The following is a description of a gene set: studied in species Homo sapiens Human Gene Set: GOBP_DNA_DAMAGE_RESPONSE Any process that results in a change in state or activity of a cell (in terms of movement, secretion, enzyme production, gene expression, etc.) as a result of a stimulus indicating damage to its DNA from environmental insults or errors during metabolism., and this is the list of marker genes: UBE2NL, FH, FANCL, INO80C, GINS4, FOXP1, AGER, IMMP2L, SLX4, IER3, CIP2A, APBB1, CRADD, PRMT6, CD44, HSF1, DTX3L, ELOF1, PCNA, FANCB (FA complementation group B), EEF1E1, UBE2E2, NPAS2, PIDD1, NSMCE3 (NCBI Gene Id 56160), INO80E, CBX5, PYCARD, FANCC, UBE2T, SUV39H1, MDM4, FANCG, OARD1, AUNIP, NKX3-1, CHEK2, FEN1, SMARCAL1, USP3, MIR193A, FANCD2, ING4, WRNIP1, ERCC3, HMGA2, DOT1L, RTEL1, RNF168, NFAT5, FUS, RPA4, ERCC6, MSH4, GFI1, KASH5, DNA2, MUS81 (NCBI Gene Id 80198), TRAF6, DNTT, GTF2H5, BAG6, SHLD2, NTHL1, EMSY, FANCM, GTSE1, MAP3K20, MMS22L, GCNA, TADA2B, UHRF1, BAD, TAOK2, PSMD10, PARP9, EGLN3, FAM111A, USP47, EP400, RNF111, XPC, FOXN3, E2F7, BRCC3, RRM2B, GTF2H4, DDX5, PRPF19, CETN2, MDC1, RFC4, TDG, LIG1 (NCBI Gene Id 3978), ZDHHC16, SMC5, PIAS1, TIPIN, HUS1B, RAD51, MCM10 (minichromosome maintenance 10 replication initiation factor), DDB1, FAAP20, PIK3R1 (phosphoinositide-3-kinase regulatory subunit 1), SGF29, MAPK14, BARD1, TPT1, TAF9B, UBE2A, RECQL5, MCM4, UBE2N, CDCA5, MCM6, CASP2, BCL7A, LYN, HPF1, BACH1, MAPK12 (NCBI Gene Id 6300), MRGBP, ACTR8, FOXO1, MIR221, MAGEF1, POLG (DNA polymerase gamma, catalytic subunit), PMS2P6, ARMT1, BCL6, ENDOV, MARCHF6-DT, RNF113A (NCBI Gene Id 7737), OOEP, PELI1, FAM168A, KDM1A, CRIP1, SEM1 (NCBI Gene Id 7979), MASTL, TDP2, PSEN1, VCP, PARG, TNF, REC8, CBX1, CXCL12, GINS2, CRY2, SETMAR, ATR, FAAP100, SMYD2, PNKP, VPS72, AP5S1, EPC2, NUDT1 (NCBI Gene Id 4521), USP45, WRAP53, WRN, STK19, HIC1, RBBP4, GTF2H1, MACROH2A1, DGKZ, SUMO1 (small ubiquitin like modifier 1), DMC1, REV3L, MUTYH, VCPIP1, ALKBH2, HMGB2 (high mobility group box 2), ZBTB7A, MIF, RHNO1, CHAF1A, INIP, BCL2L2, IFFO1, ASTE1, CDKN2A, EXO1, MBTPS1, HNRNPK, DYNLL1, ANKRD1, SNAI1, ZBTB38, RAD9B, TELO2, SPATA22, METTL3, SMARCD1, SETD1A, BCL7C, UPF1, MTREX, POLI, CBX8, DDX1, ERCC5, NRBP2, CDKN2D, FBXW7, ABRAXAS1, CDC14B, KDM2A, NFATC2, CCAR2, WAS (NCBI Gene Id 7454), PPP2R5C (NCBI Gene Id 63377), RPS6KA6, PIAS4, ATM, KAT5, DONSON, RPTOR, DCLRE1C, PLK5 (NCBI Gene Id 126520), BAZ1B, BRCA2, NABP1, TENT4A (terminal nucleotidyltransferase 4A), ZC3H12A, MGME1, CHAF1B, POLQ, RNF138, OGG1, GTF2H3, TOP3B (DNA topoisomerase III beta), ERCC2, DELE1, RFC3, MTOR, APTX, SENP3, ARID1A, MEIOC, XRCC2, MCTS1, SHISA5, WNK2, EPHA2, RAD21, RPA1, CHD1L, SKIL, MACROD2, PYHIN1, PRDM9 (PR/SET domain 9), TIGAR, HDGFL2, SKP2, MAPKAPK2, MEAF6, NFATC4, GIGYF2, POLK, TAF1, NSD2, TAF5, SPINDOC, SNW1, NRBP1, MCRS1, TRIM28, EIF2AK4 (NCBI Gene Id 440275), SPDYA, MLH1, HTATSF1, PMS2, SFRP2, CHCHD6, RPS27L, RAD54L, REV1, IRF7, INO80B, SPO11, XNDC1N, TADA3, KIF22, POLD2, RNF126, FBXO31, C1QBP, TANK, POLM, MARF1, RMI1, DHX9, STUB1, NRDE2, C11orf54, ACTB, UVRAG, RECQL4, ZCWPW1, MORC2, MAD2L2, TAOK3, TIMELESS, CEBPG, SUPT7L, CLU, ZNF668, TAF6, PDS5A, SPIRE2, NEIL2, SUSD6, RAD23B, CSNK2A2, ACER2, NFRKB, SGK1 (NCBI Gene Id 6446, serum/glucocorticoid regulated kinase 1), KIN, SIRT4, PLK3, HELQ, MRNIP, TONSL, TP53BP1 (NCBI Gene Id 7158), CCNK (cyclin K), SMCHD1, TOP3A (DNA topoisomerase III alpha), USP43, XRCC1 (X-ray repair cross complementing 1), USP10, FAAP24, BCL7B (BAF chromatin remodeling complex subunit BCL7B), SMUG1, KDM4D, BAK1, ASCC3 (activating signal cointegrator 1 complex subunit 3), ING2, CHD2, BCL2L12, PARPBP, POLR2I, UNG, CD74, BLM, MAEL, PPP4C, PMS2P5, UCHL5, SMARCB1, PCLAF, ATXN7, MDM2, INTS7, ZNHIT1, RRM1, ERCC8 (NCBI Gene Id 2075), RUVBL1, ZBTB1, SIRT1, CTBP1-DT, FIRRM, WNK1, H2AX, MSH3, TNFRSF1A, YAP1, RASSF1, TREX2, CSNK1E, NUDT16L1, SIRT7, FBXO6, RIOX1, TTI2, ELL3 (elongation factor for RNA polymerase II 3), PRAP1, VRK2, TAF4, BRD4, TFPT (TCF3 fusion partner), ERCC6L2, XRCC3, UBA1, CDK9, LIG3, NUAK1, PIF1, CUL4A, NOP53, PHLDA3, RPS3, FBXO4, PSME4, JMY, IRF3, UVSSA, TOP2A, TMEM109, NDUFS6, UBE2W, CSNK2A1, YY1, MCMDC2, RAD9A, TAF12, WDR33, ZRANB3, CCDC117, CREBBP, CDK1, MAJIN (membrane anchored junction protein), TFDP3, PTTG1, PPP1R15A (protein phosphatase 1 regulatory subunit 15A), PML, RINT1 (NCBI Gene Id 60561), MCM2, TAF10, SETD2, NYNRIN, SMARCAD1, WDR76, DDIAS, BAX, ERCC6L, USP9X, ABL1, CFAP410, MAP2K6, MSH2, ZBTB4, TAF7, TERF2IP, ACTL6B, IKBKE, APLF, BID, SMC1A, TNP1, HIPK2, VRK1, FBH1, RAD17, DDB2, AP5Z1, ATAD3A, OTUB1, NEIL3, MARCHF7 (NCBI Gene Id 64844), BCL2L11, XIAP, PPP1CA, PARP10, SMARCD3, MTA1, FBXO45, SMG1, PHF13, SPRED2 (sprouty related EVH1 domain containing 2), TRIAP1, SMARCC1, E2F1, WDR4, SETD7, RFC5, FOXO3, CENPX, PAXX, FBXO5, TNKS1BP1, BRD7, UBQLN4, CCND1, USP1, HTRA2, COPS3 (COP9 signalosome subunit 3), USP51, NSMCE2, MAPK3, NUPR1, HDAC10, NSMCE1, MPND, PTTG1IP, FOXO4, FGF10, HLTF (NCBI Gene Id 6596), EP300, NEK4, RBBP6, CDK6, ALKBH7 (NCBI Gene Id 84266), SLF1, PPP4R3C (NCBI Gene Id 139420), TTC5, ZNF432, ZNF830, HELB (DNA helicase B), EYA3, CEP164, CEP63, NCOA6, CDIP1, CDC7, SFN, NACC2, MCM8 (NCBI Gene Id 84515), BABAM2, TAF6L, CDK3, TLK1, UIMC1, XAB2, CLOCK, TERF2, UBE2D3, BOD1L1, PALB2, UBE2U, ATXN7L3, PAGR1, POLH, INTS3, CHEK1, XRCC6, MRE11, RAD23A, EME2 (essential meiotic structure-specific endonuclease subunit 2), ASH2L (NCBI Gene Id 9070), SMARCC2, PAXIP1, LIG4 (DNA ligase 4), TLK2, EXO5, RBM24, FLYWCH1, POLE, NEIL1, RADX, CYREN (NCBI Gene Id 78996), TAOK1, MOAP1, RAD52, ACTR5, ZSWIM7, MSH5, MCL1, WDHD1, CINP, KHDC3L, RBBP8, TRIM39, DCLRE1B, RAD51B, PARK7, TTI1, NEK11, MLH3, ATRX, ATP23, FMN2, USP44 (NCBI Gene Id 84101), CUL4B, INO80, GNB1L, TRIP12, RBM38, COMMD1, MLST8, ZMYND8, SNAI2, DDX11, MCM7, EYA1, ING3, EYA4, TIPRL, SHLD3, USP28, ATF2, MGMT, FANCE, SLX1B, TADA1, POLL (DNA polymerase lambda), PRIMPOL, SPRED1, DEK, NUPR2, CDK2, HINFP (histone H4 transcription factor), BATF, CHRNA4, SDE2, POLA1, POGZ, BRD8, PHF10 (NCBI Gene Id 55274), INO80D, MCM9, AIM2, PPP4R2, MPG, CRY1, PRMT1, YEATS4, UBR5, MBTPS2, SYCP1, EI24 (EI24 autophagy associated transmembrane protein), CDKN1B, CSNK2A3, VAV3, PARP3, MIR34A, SFPQ, POLD3, CIDEB, SHLD1, DCLRE1A, STK33, TOP2B, FNIP2, RPA3, FZR1, TP63, MTCH2 (mitochondrial carrier 2), SWI5, TICRR, CASP9, CASP3, BCL3, WNK3, TFAP4, CHD4, FMR1, UBA6, WDR48, TERB2, HUS1, CGAS, CDC5L, BRCA1, FOXM1, HMCES, NEDD4, SLC30A9, HIPK1, ENY2, UBE2V1, SOD2, HDAC3, SPRTN, VRK3, POLN, SPIRE1, RFWD3, EGFR, DYRK3, SHPRH, CLSPN, STK11, SYF2, UBE2B, PRKCG, ARID1B, TAF2, HUWE1 (NCBI Gene Id 54789), PRKCD, ATRIP, POLDIP2, TP53, UBA7, HMGB1, BOK, ADPRS, TWIST1, RIF1, MICA, DPF1, PRKDC, NBN, GTF2H2C_2 (NCBI Gene Id 730394), MEIOB, OTUD4, TAF5L, SUPT20H, NIPBL, BCL2, DMAP1 (DNA methyltransferase 1 associated protein 1), ZMAT3, APC, EPC1, FANCA, SETX, SOX4 (SRY-box transcription factor 4), PMS2P1 (NCBI Gene Id 5386), GTF2H2C, ALKBH1, RBX1, XRCC5, ALKBH8, POLD1, KMT5A, TDP1 (NCBI Gene Id 55775), MAPT, MC1R, CENPS, DYRK1B, APEX1, DDIT3, ETAA1, SMARCA4, TOPBP1, FEM1B, GADD45A (growth arrest and DNA damage inducible alpha), NDRG1, SMARCD2, POLE2, MCM5, PLK1, ERCC1, POLE3, PPP4R3A, RNASEH2A, POLD4, EXD2, RNF8, NPM1, SIRT6, HSF2BP, AEN, ZMPSTE24, SFR1, RPL26, NEURL4, RNASEH2B, SUPT16H, SESN2, ZGRF1, WNT1, TMEM161A, SLF2, MORF4L1, MBD4, XPA, RAD54B, MSH6, RAD21L1, RAD51C, POT1, MCM3, SPIDR, SF3B5, NUCKS1, GTF2H2, MACROD1, FANCI, ENDOG, GML, MUC1, USP7, TFIP11, STK38, SAMHD1, RUVBL2, BRIP1, RFC1, RAD18, HMGN1, MBTD1, PARP4, DCUN1D5 (defective in cullin neddylation 1 domain containing 5), UFL1, CBX3, BBC3, ATXN3, HMGA1, SMC3, ARID2, DPF2, PARP2, FIGNL1 (NCBI Gene Id 63979), ANKLE1, ESCO2, TREX1, SLX1A, TEX264, GNL1, CDKN2AIP, BRAT1, NABP2, WAC, PBRM1 (NCBI Gene Id 55292), FAN1, BTG2, CCDC13, SMC6 (structural maintenance of chromosomes 6), PPP1R10, CDK5RAP3, REXO4, TNFRSF1B, MSX1, CDKN1A, ACTL6A, ACTR2, MAPK15, PIERCE1, PPM1D, USP22, SF3B3, ASF1A, NHEJ1, RPA2, ASCC2, PSMD14, CTC1, KMT5B, RNASEH2C, SMARCA2, TRIP13, BCLAF1, PPP5C, PARP1, PMS2P3, ALKBH3, ACKR3, MYC, PLK2, DYRK2 (dual specificity tyrosine phosphorylation regulated kinase 2), PDS5B, GGN, POLB, MEN1, ZBTB40, TRRAP, CBL, RMI2, FTO, GRB2, NONO, ACD, TAF9, BCL2L1, MMS19, SP100, EME1, SMARCE1, ERCC4, EEPD1, MORF4L2, MNDA, BCCIP, H2AC25, PWWP3A, RECQL, TERB1, EID3, TTF2, RAD51AP1, DTL, TOPORS, RFC2 (NCBI Gene Id 5982), RNF169, BABAM1, DYRK1A, UACA, IFI16, DDIT4, MSL2, PMS1, PHF1, TEX12, KAT7, SWSAP1, PPP4R3B, AXIN2, PAK1, ZNF385A, ZNF365, BCL2A1, XRCC4, STXBP4, PTPN11, TEX15, KAT2B, DGCR8, EYA2, C14orf39, ATAD5, SMARCA5, CTLA4, TP73, GEN1, CDK7, FANCF, SLFN11, ASCC1, HROB, KAT2A, YJU2, MAPK1, PLA2R1, SSRP1, MNAT1, USP16, BCL2L10, RCHY1, SUPT3H, KMT5C, HERC2, MYO6, ATMIN, URI1, APEX2, EXOSC10, PMAIP1, IKBKG, TRAIP, RAD1, BRME1, RAD50, TRIM32, BRSK1, CDC45, UBE2V2, NME3, KLHL15, ZFYVE26, AKTIP, RAD51D, NSMCE4A, DPF3, CIB1, RBBP5